The following is a description of a gene set: from publication Torelli GF, Maggio R, Peragine N, Chiaretti S, De Propris MS, Lucarelli B, Screnci M, Mascolo MG, Milano F, Iori AP, Girelli G, Guarini A, Foà R (PMID 21732086) Human Gene Set: GSE22501_PERIPHERAL_BLOOD_VS_CORD_BLOOD_TREG_DN Since the role of cord blood (CB) regulatory T cells (Tregs) for the suppression of the allogeneic T-cell response is under investigation, we analyzed and compared the functional properties and gene expression profile of Tregs expanded from CB units or from the peripheral blood (PB) of helathy donors. Tregs were purified from 23 CB units and from the PB of 13 donors and expanded for 6 days with anti-CD3, anti-CD28 and IL-2. Immunophenotypic analyses were performed, and suppressor activity of expanded Tregs was measured in mixed lymphocyte reaction (MLR) cultures. The IL-10 production capacity was tested and gene expression profile experiments were performed on 6 Tregs from PB and 4 from CB. CB and PB Tregs had similar immunophenotypic features. Tregs from CB presented a higher expansion capacity and genomic characterization showed in CB-derived Tregs a significant enrichments of genes involved in cell proliferation, chromatin modification and regulation of gene expression in CB-derived Tregs. All samples were positive for the Foxp3 gene and protein after expansion. CB and PB expanded Tregs exerted a comparable and potent suppressive function of MLR and presented a high in vitro IL-10 production capacity. Gene profile analysis also revealed for PB Tregs a significant enrichments of genes involved in the adaptive immune response. Genes down-regulated in T reg from: peripheral blood versus cord blood. species: Homo sapiens, and this is the list of marker genes: RASAL2, SPATA31F2P, GFI1, IL10RA, CT62, SPINT2, TRIB2, S100P, G6PC1, ANAPC13, KCTD12, HDAC6, P2RY14, IDE, NID1, OAT, TRIM52, PNLIPRP2, GOLGA8A, IL1RN, ETFB, CCR8, RFK, GPAA1, PTGER2, GLB1L2, PLA2G4A, RGR, PLPP1, S100A11, SURF2, BTF3P12, EPO, LRP6, TMEM131L, TRPC6, CDK6, EFR3B, SUZ12, CA5BP1, PTPRZ1, SLC11A2, RPL32, PLEKHB2, SLC39A8, FMOD, TMPRSS11D, PPP2R3A, CD47, KHDRBS1, CENPS, CCL4, HPRT1, AVPR1A, GUCY1A2, ZFP36L1, PRKX, CRIPTO, EPAS1, SERPINC1 (serpin family C member 1), ACTC1, RPA1, H2BC21, KLRG1, SOCS1, CEP43, NCAM1, USP24, ARAF, SERPINB3, SELP, ATF5, RIPK2, IRF9, IL4R, RETREG3, CHL1, USP6NL, VCAN, BMP6, BRDT, S1PR1, HBEGF, MAP3K14, ABCC2, EVI2A, LRRN3, CCNB2, SDCBP, MED13, SCAMP5, RORC, GPR183, FCGR3B, SPINK2, BCAS2, ZDHHC17, SLC22A2, EFNA2, ADAM17 (NCBI Gene Id 6868), SCD, TMEM47, STARD8, PTPN1, CCDC144A, FOXC1, ACD, EEF2, SLC2A2, ZDHHC18, SELL, NAPG, DARS1, ALOX5AP (NCBI Gene Id 241), BCL2L11, PTPRE, SLC25A24 (NCBI Gene Id 92093), IL18, MGAT1, GIT2, FGL2, NME6, KDM7A, TTC39A, SIRPB1, DYNLT1, LRCH1 (NCBI Gene Id 23143), REN, GPSM2, FARP1, CGGBP1, AKR1D1, EVI2B (ecotropic viral integration site 2B, NCBI Gene Id 2124), XBP1, RSRP1, IL10, WNT11, HFE, PENK, GRK3 (G protein-coupled receptor kinase 3), LAMA4, PON3, SLC36A1, IMMT, EMX2, CSPG5, SPEN, WRN, WDFY3, CLC, IL18RAP, C2CD5, TUT4, IGSF3, HPD, MEST, KRT31, DLGAP5, MAPKAP1, CCR5, C3AR1, DLAT, MAGEA5P, IDH1, GPR107, GYS2, CD8B, OR7A5 (olfactory receptor family 7 subfamily A member 5), IL12A, FLRT2, HR, LSM1, AKAP5 (A-kinase anchoring protein 5), EPS8, SACM1L, OTUD3, SLA, CCL3, REEP5, CLCN2, REST, NFIL3, NDUFB5, CEMIP, TRIM33, ITGA9, LCP2, ABHD5, SOS2, S100A7, NEFH, TP53BP2, ZFR2, PHKG2, KLHL18, UGT2B4, USP9Y, CHST10, FXR1